Given this list of marker genes NTRK1, TAGLN3, SYT4, TFAP2B, PAX6, MIR124-1HG, PLXNA2, ONECUT2 (NCBI Gene Id 9480), NNAT, CD24, JPT1, NDRG4, RTN1, STMN2, SOX4, ADD2, NSG2, CACNG3, STMN4, CNTNAP2, MIAT, PTF1A, MAGI1, SCN3A, MLLT11, MIR124-2HG, PTPRF, TFAP2A, MEIS1, SULF2, ONECUT1, RORB, TUBB2B, TUBA1A, INA, STMN1, MGARP, PROX1, CRYGD, ONECUT3, here is a description of the gene set: Human Gene Set: HU_FETAL_RETINA_HORIZONTAL Horizontal Cells from publication Hu Y, Wang X, Hu B, Mao Y, Chen Y, Yan L, Yong J, Dong J, Wei Y, Wang W, Wen L, Qiao J, Tang F (PMID 31269016) studied in species Homo sapiens